Given this list of marker genes FAM120A, WDR47, PCDHGA7, RASGRP3, PRLR, HOXA3, FSD1L, MGAT2 (NCBI Gene Id 4247), KIAA1143, NFIB, LRRC8C, SLC25A34, LYRM7, IGF2BP3, PCDHGA2, GABRG3, UGT2B10, BRWD3, TRIM59, TFCP2, MOSPD1, AGA, AFF1, ZNF618, DENND1B, MAGI1, GAS1, PRIMPOL, ZNF493, TLK2, QSOX2, MTF1, ABI1, NFAT5, HDAC2, ZNF704, VKORC1L1, DCUN1D1, STK39, TLCD4, CXCL3, ZNF814, PCBP1, SATB1, ZNF772, LCOR, GADD45A, KLHL15, RPS6KA6, ROCK2, RCC2, SFR1, TPMT, KLHDC10, RASGRP1, SERTAD2, PGRMC1, SF3B1, DSC2, UBR2, DAZ4, GSK3B, ALCAM, DAZ2, TRAPPC10 (NCBI Gene Id 7109), RNF217, APPBP2, SLC44A5, MAP4, CAV2, TOR1A, SPDYA, HAND2, FAM133B, SLF2, FGF23, ZBTB6, MTCL1, A1CF, ADRA1A, FZD4, LUC7L3, C3orf70, GOSR1, HELZ, IL31RA, SIX4, DENND4C, FAM222B, TRPM7, DLG3, SGMS1, MED28, DR1, LCORL, LGR5, SHCBP1L, TRIM9, SLC16A1, CADM2, ZBTB21, CTCFL, TXNRD1, SERP1, SCHIP1, HECTD2, CNTNAP4, KLF4, PIK3CB, CAMTA1, CNOT6L, LCP2, FAM110B, METTL14, LRRC1, LRIG2, TIPARP, FILIP1, U2SURP, RAD23A (NCBI Gene Id 5886), BCAP29, DACH1, SASS6, HERPUD1, CSTF3, AGBL4, RBM47, CCSER2, TMEM123, LNPK, TXK, ARHGAP32, GUCY1A1, ADAMTS18 (ADAM metallopeptidase with thrombospondin type 1 motif 18), MYO1B, TOP2A, TCF7L2, SERINC5, CDKN3, DTWD2, RAB3C, DERL2, EML2, INPPL1, ZNF620, EVI5, USP53, ATXN3, ZNF280B, TCEAL9, MAP2, GPR22, RAB27B, NXPE1, TMCC1, FKBP1A, ACKR4, RRM2, MTDH, DCTN5 (NCBI Gene Id 84516), NAV3, NRK, ROBO2, TAF2, FRA10AC1, SREK1, SLC1A3, MARCKS, OLFML2B, JAKMIP2, UTY, GLIS3, TNFSF8, STK17A, REST, ATRX, PPP4R2, ZNF148, CNTLN, CDC42BPB, ST8SIA4, ATAD2B, CTDP1, THAP2, FRMD3, CSK, TMEM158, MTMR6, MFSD14B (major facilitator superfamily domain containing 14B), TFAP2A, CDK6, TRUB1, HACD1, RAPGEF5, ZNF396, JMY, RBBP7, MED30, ARHGAP21, ONECUT2, TSEN2, RPRD1A, WAPL, TJP2, PPIL3, CD302, C1R, MTX3, DPPA5, SPCS1, COLCA1, GDPD1, PSEN1, DBT, SPICE1, PCBP2, DAZ3, PRKCA, PIAS1, CALHM5, KRAS, ERP44, SHOC2, PPP4R3B, STYX, NOVA1, UACA, HERPUD2, FCHO2, AAK1, C17orf75, ANAPC1, SORCS1, INCENP, CCDC186, DYRK2, ZFHX3, ARFGEF1, SGIP1, TRIM23, RIPK2 (receptor interacting serine/threonine kinase 2), OCLN, DCP1A, SLC2A13, ZBTB33, WDR41, TTPA, SKIL, ICE2, FAM53C, HLTF, CTAGE1, DYNLT5, ADD3, MRE11, ZFAND4, AP4S1, GPALPP1 (GPALPP motifs containing 1), C1GALT1 (NCBI Gene Id 56913), CLVS2, BMPR2, ZNF280C, PCK1, ABCD4, CRHR2, AGO4, FBXL3, KHDC4, PCDHGA12, TP63, GPR63, SMAD6, LIN7A, MRGPRX2, CSDE1, BACH2, ZNF100, CDCA4, TMEM255A, GNL3L, ADAMTS19, DSG2, LCLAT1, CRYBA1, SLC39A10, LONRF2, TYW3, CTSB, MAML1, METTL25B, EYS, RNF38, DNM3, ACP7, NR3C2, CYRIB, IKZF2, BCL10, TRIM33, EXOC8, HNRNPR, PAGE2B, AVL9, ADCY2, PPM1B, SEC62, WASF3, SUB1, CRMP1, PTPRK, RAP2B, ATL2, TAOK3, SGCZ, NBEA, ATRNL1, FYB1, PCDHGA10, PLAGL1, SUPT16H, PLPPR1, SLC25A16, SPRY2 (sprouty RTK signaling antagonist 2), OPHN1, PSPC1, ZNF555, IDE, WDR64, RNF138, ADGRL1, GIMAP1, URI1, THUMPD1, PHF3, NINL, CREB1, SLC22A7, PIGP, KIF2A, GABRG1, CDK19, SRSF1, CPEB1, THSD7A, SPC25, PCDHGA9, PIN4, YOD1, KALRN, TRIM5, VCPIP1, GPM6A, MIEF1, SHISA3, KANSL1L, NR4A2, FRY, INSIG1, PBRM1, ARPC3, MYOF, TOX3, TET1, MAB21L2, PDLIM2, ZFX, ANKRD28, RPF1 (ribosome production factor 1 homolog), ESYT3, NEXMIF, KIF3B, CDC14A, CTSC, ARK2N, COL5A1, SPTLC2, RPGRIP1L, WDTC1, TMEM74, FBXL2 (NCBI Gene Id 26008), GCNT1, STC2, ANGEL2, FAM76A, JRKL, ELK4, LPIN2, MPZL3, ADGRL2, PAGE5, OSBPL8, MBLAC2, LRRC28, HMGCS1, ZMYND11, STARD4, MZT1, HTR2C, MAPK4, ANO5, ACVR2B, MED12, B4GALT6, TRIM60, HOOK3, CDKL2, DSCC1, IQCJ-SCHIP1 (NCBI Gene Id 100505385), TNPO1, ARPP19, ELAVL1, TMEM38B, SNRPD1, SYTL2, SUGCT, SOHLH2, ZNF652, PAGE2, EVI2B, PHC3, ZYG11B, QKI, COL24A1, TNFRSF9, PCDHGB3, KIAA0319, MEX3B, ZNF711, DCK, SH3BP2, MAP3K2, PNISR, RNF19B, TIAL1, ERICH3, ZNF468, CCDC169-SOHLH2, PSIP1, SCAMP1, MIER3, DDX3X, PPAT, SOX2, TRMT13 (tRNA methyltransferase 13 homolog), LRP6 (NCBI Gene Id 4040), KDM5B, ESYT2, CHSY3, NUFIP2, IFT81, ABHD6 (NCBI Gene Id 96026), DGKH, CC2D2B, PLD5, SEH1L, MYEF2, PPM1A, ZNF606, ZFPM2 (zinc finger protein, FOG family member 2), RUNX1, CTBS, COIL, AGFG1, SINHCAF, REV1, KCNN3, LY75-CD302, SLMAP, SCG2, AMER2, ZNF680, PAIP1, RYK, GPATCH2L, ATG14, PPP3CA, ELMOD2, INO80D, MED10, RAD21, GPR85, CTTNBP2, USP33, LCA5, MED13L, KLF9, ATXN2, CCDC117, TIAM1, ZBTB41, KBTBD8, NUDCD1, PCDHGA11, PATZ1, RHOF, SEL1L, PPP3R1, INAFM2, OPRM1, DKK3, CNTN1, SLC7A11, GUCY1B1, C17orf58, MEX3D, PCDHGA5, ZNF780B, SLC9A4, ARFGEF2, LATS1, TRIP11, PGM3 (NCBI Gene Id 5238), CGGBP1, PCDHGA3, FAM169A, MATCAP2, PCDHGB7, CCNC, SCNN1G, NEMP1, SESN3, HERC4, TRPS1, SPRED1, STK4, RBM24, SPIRE1, DCUN1D5, CD47, PCDHGA1, LUZP4, L3MBTL3, CYSLTR1, ZNF518A, AMFR, IL20, CDK13 (NCBI Gene Id 8621), HYCC2 (NCBI Gene Id 285172), PARG, ZNF736, PABIR2, PIAS2, ARL14EP, CELF5, ATXN1, ZNF175, WNT5A, SLC12A2, YWHAZ, ZZZ3, EDEM3, TMED5, STT3A, KLHL4, BCLAF1, GLCE, UBE2D1, CMPK1, MMP10, CYP3A4, ZDHHC21, TRIP12, BRWD1, BCLAF3, BCL11A, PCDHGC3, OTUD6B, PHF2 (NCBI Gene Id 79448), DAXX, PTAR1, GUCY1A2, COL19A1, ZNF713, PLRG1, TOX2, C2orf88, RUFY2, PJA2, LARGE2, WEE1, RAB39A, NRXN1, TAL1, FOXN2, PTPRG, PCDHGA8, ENOPH1, ZNF860, TVP23B, MED13, STXBP5, DPY19L1, KCNH1, CNTNAP2, BAIAP2, B3GALT2, DAZ1 (deleted in azoospermia 1), GFPT1, CDC14B (NCBI Gene Id 8555), TP53BP1, TTC19, SNAP91, CRTC3, TCF20, ZFYVE28, SH2D4B, SLC7A14, ERCC6, SRP72, NLK, ZBTB20, SREK1IP1 (NCBI Gene Id 285672), PPIG, RBMS3, XK, DNAJB14 (DnaJ heat shock protein family (Hsp40) member B14), TFRC, SPAG9, RSBN1, ACKR3, RSKR, BBS7, CPB2, PRDM2, GRIA2, MAFB, CENATAC, CXADR, GJA1, PAPOLG, PARD6B, PAFAH1B2, SMARCA1, CBFB, NFKBIZ, COL5A2, ABCB10, ASNSD1 (NCBI Gene Id 54529), FAM76B, PPP1R12B, ACVR1B, OTULINL, ARRDC3, FNDC3A, SHPRH, CD164, NSL1, NT5C3A, PCDH7, RHEX, NEK7, SAMD8, PHIP, RAP2A, ADAMTS5, CCAR1, RNPEP (arginyl aminopeptidase), SHC1, MAPDA, EPHA5, DGLUCY, SCAI, RAPH1, TDG, PHF20L1, MKLN1, THUMPD3, MREG, SELENOF, ETNK1, SHC4, TASOR, STIM2, ATXN7, here is a description of the gene set: studied in species Homo sapiens Human Gene Set: MIR5582_3P Genes predicted to be targets of miRBase v22 microRNA hsa-miR-5582-3p in miRDB v6.0 with MirTarget v4 prediction scores > 80 (high confidence targets). from publication Chen Y, Wang X (PMID 31504780)